The following is a description of a gene set: species: Homo sapiens Genes having at least one occurence of the motif AAAGGGA in their 3' untranslated region. The motif represents putative target (that is, seed match) of human mature miRNAs hsa-miR-204 and hsa-miR-211 (v7.1 miRBase). Human Gene Set: AAAGGGA_MIR204_MIR211, and this is the list of marker genes: ATF2, ALPL, ZCCHC14, ZNF282, FBN2, CPNE8, MRPL35, SLITRK4, MAML3, TP53INP1, SUMO2, FRAS1, RSPO3, DAG1, GGA2, HS2ST1, AP1S3, CORO1C, ZNF335, CPD, ITPR1, GRM1, FREM1, SOCS6, COX5A, KLF12, TRPC5, ARL8B, TCF7L1, ARAP2, GLIS3, MAP1LC3B, SATB2, FJX1, IGF2R, SERINC3, CTDNEP1, SEC24D, TCF12, ARHGAP29, CCDC120, SZRD1, MMGT1, APH1A, ELOVL6 (ELOVL fatty acid elongase 6), MRPL52, CELSR3, PRRX1, ZFC3H1, GAPVD1, CCNT2, ADAMTS9, AP3M1, NOVA1, BCL9, ELAVL3, NR3C1, GPM6A, WEE1, TMOD3, WNT4, SEC61A2, PPP3R1, CDH2, ZDHHC17, CLIP1, SF3B1, KMT5A, EFNB3, BCL9L, SIN3A, CHP1, GABRB3, ANXA11, EPHA7, BCL11B, P4HB (NCBI Gene Id 94756), SMOC1 (SPARC related modular calcium binding 1), RAB1A, POU3F2, ST7, TRIAP1, RTKN2, ESR1 (NCBI Gene Id 2099), SGIP1, ELMOD3 (ELMO domain containing 3), FRY, JPH3, CHD5, BCL2, MLLT3, SLC37A3, RHOBTB3, MBNL1, SOX11, NTRK2, RAB10, BAZ2A, KCNA3, SSRP1 (NCBI Gene Id 6749), WSB1, TGFBR2, FBXW7, CRKL, SPRYD7, NBEA, METAP1, RHOT1, AP1S1, MON2, MIR600HG, DHH, EZR, PRPF38B, RPS6KA3, RAP2C, RPS6KA5, PHF13, PABIR2, USP6, YTHDF3, UBE2R2, ING4, KHDRBS3, ADPRM, AGO4, RICTOR, PLAG1, TAF5, DLG5, DENND5A, CDC25B, SLC22A2, NPTX1, ELF2, TNRC6B, DTX1, NR4A2, PPARGC1A, DNM2, RUNX2, XRN1, DNAJC13, SLC17A7 (solute carrier family 17 member 7), RBSN, TRIP12, MYO10, CDC42, KDM2A, LRRC8D, ZCCHC24, EVA1C, MALL, PID1, KITLG, KHDRBS1, ARGLU1, CHN2 (NCBI Gene Id 644086), HMGA2, ADCY6, SPRED1, NRBF2, TTYH1, DVL3, STXBP5, CAPRIN1 (cell cycle associated protein 1), FAM120C, PCDH9, FHIP1B, MAP3K3 (mitogen-activated protein kinase kinase kinase 3), KCTD1, DMTF1, SHC1, AUP1, AKAP1, YWHAG, ANGPT1 (NCBI Gene Id 284), NAA15, ZFP91, HAPSTR1, HIC2, RPS6KC1, NEUROG1, RAB14, ARCN1 (NCBI Gene Id 372), CREB5, UHRF2, CCPG1 (NCBI Gene Id 9236), FAM117B, ELL2, AP2A2, LATS1, PRDM2, MED13L (NCBI Gene Id 23389), DCAF5, DCUN1D3, SPOP, FNIP1, RERE, LPAR1, ABRAXAS2, ATP2B1, EDEM1, ESRRG, BRPF3, SUMO4, EPHB6, KLHL13, EEF1E1, NCOA7, BRD4, SLTM, SCRT2, HOOK3, DYRK1A (NCBI Gene Id 1859), ANKRD13A, KMT2A, SGCZ, ZNF423, SIRT1, SOX4, REEP1, TMEM30A, HOXC8, FARP1